Given this list of marker genes Kras, Gpcpd1, Car1, Tmem52b, Pou2af2, Ago1, Fancl, Arhgef6 (NCBI Gene Id 76697), Zfp513, Pip4k2a, Maneal, Tmtc2, Sfmbt1, Map3k14, Smagp, Cisd2 (CDGSH iron sulfur domain 2), Gpr85, Nucks1, Ubl3, Fubp1, Nfatc3, Fryl, Serpinb8, Slc35g2, Gid4, Ubxn7, Onecut2, Exosc9, Scn4b (NCBI Gene Id 399548), Med13, Amph, Trim52, Rnpc3, Epha7, Gfap, Moxd1, Adck2, Lipt2, Cav2, Timm44, Sqle, Ccdc3, Adal, Brinp3, Idnk, Nfia, Naaladl2, Sbno1, Mnat1, Smarcad1, Usp14, Yy1, Daam2, Slc30a4, Pgap1, Sp4, Mmgt1, Erv3, Tenm3, Zmym3, Zfp655, Dennd4a, Phf20l1, Ccnj, Rapgef2, Dpysl2, Itgb1, Saysd1, Tgfbr1, Polr3e, Lrrc40, Nfat5, Cdk13, Tshz3, Foxf2, Srpk2, Stmn2, Eif4a2, Cds2, Ddx17, Srgap3, Laptm5, Prpf4b, Med13l, Stard4, Me2, Megf9, Ptprr, Dyrk1a, Plekhb2, Ezh1, here is a description of the gene set: from publication Chen Y, Wang X (PMID 31504780) Mouse Gene Set: MIR_6357 studied in species Mus musculus Genes predicted to be targets of miRBase v22 microRNA mmu_miR_6357 in miRDB v6.0 with MirTarget v4 prediction scores > 80 (high confidence targets).